Given this list of marker genes TRBJ2-5, TRBJ1-4, OR9A3P, TRBV4-2, CLCN1, TRBV6-6, TRBV12-1, MIR6892, SVOPL, TRBV5-2, RN7SL771P (NCBI Gene Id 106481132), NDUFB2-AS1, FMC1, RNU1-82P (NCBI Gene Id 106480175), FAM131B-AS2, OR6V1, DENND11 (DENN domain containing 11), ZC3HAV1, LUC7L2, RNU6-911P, RNU6-1272P, TRBD1, TRBJ1-1, KIAA1549, TRBC2, TRBV29-1, TRBV15, ENSG00000252188, KEL (NCBI Gene Id 3792), TRBV7-5, TRBV6-5, RN7SL481P, TAS2R39, PRSS3P1, PRSS59P, TMEM178B, TRBV12-4, CCT4P1, RNU1-58P, SLC37A3, TRBVB, TRBV6-2, BRAF, TRBJ2-3 (T cell receptor beta joining 2-3), TRBJ2-7, TRBJ2-4, AGK-DT, TRBV5-3, TRBJ1-5, TRBV12-2, TRBV23-1, MGAM2, RPL21P73, MSL3P2, EPHB6, RAB19, LLCFC1, TRBV11-3, RNU6-85P, MTND2P5, UQCRFS1P2, TRBV1, RPL17P28, MTND1P3, MOXD2P (NCBI Gene Id 642128), TRBV8-1, TRPV6, TRBV18, TRBV22-1, TRBJ1-2, PRSS2, OR9N1P (NCBI Gene Id 81383), TRBV16, RNU4-74P, ZC3HAV1L, TRBV13, UBN2, TRPV5, TRBV6-7, TRBV5-7, PPP1R2P6, KDM7A, TMEM139-AS1, GSTK1, ZYX, TRBV9, OR6W1P, TAS2R6P, ADCK2, TRBV12-3, MTCO1P55, TRBV30, WEE2, RNA5SP247, TRBV20-1, TRBV7-4, ENSG00000307342, TRBJ1-3, KLRG2, TMEM213, ERHP1, PRSS1, TRBV5-4, TRBV8-2, TRBV5-5, TRBJ2-2, TAS2R38, NDUFB2, TRBV5-6, HIPK2, WEE2-AS1, TMEM139, TRBC1, KDM7A-DT, RNU6-206P (RNA, U6 small nuclear 206, pseudogene), MKRN1, TRBV4-1, TRBV6-8, TRBJ2-1, TAS2R40, TBXAS1, TRBV7-1, TRBV7-9, TRBV7-2, TRBJ1-6, TRBV10-2, IFT56, TAS2R3, WBP1LP1, HINT1P1, MRPS33, ATP6V0A4, PGBD4P1, FAM131B, CASP2, OR9P1P, TRBV14, TRBV25-1, TRBJ2-2P, MYL6P4, RN7SL535P, TRBV2, PRSS58, PRSS37, OR9A1P, TRBV17, TRBV6-1, TRBJ2-6, TRBV24-1, RNU6-797P, TRBV26, TRBV19, TRBV10-3, DENND2A, RPL17P27, PRSS3P3, FMC1-LUC7L2, TRBV28, TRBV10-1 (T cell receptor beta variable 10-1), TRBV12-5 (NCBI Gene Id 28575), TRBV11-2 (NCBI Gene Id 28581), TRBV7-6, CLEC2L, MGAM, TRBV7-3, AGK, NDUFB10P2, SSBP1, TRBV3-1, PARP12, TRBVA, CLEC5A, TRBV6-4, OR9A2, TRBV7-7, TAS2R5, TRBV5-1, OR9A4, RNA5SP248, PIP, TRBV11-1, TRBV27, TAS2R4, TRBV21-1, MZT1P2, FAM131B-AS1, here is a description of the gene set: species: Homo sapiens Human Gene Set: chr7q34